The following is a description of a gene set: Any process that activates or increases the frequency, rate, or extent of production of transforming growth factor-beta1. Human Gene Set: GOBP_POSITIVE_REGULATION_OF_TRANSFORMING_GROWTH_FACTOR_BETA1_PRODUCTION species: Homo sapiens, and this is the list of marker genes: THBS1, LUM, CX3CL1, FOXP3, SERPINB7, ATP6AP2